Given this list of marker genes CASP8, UNC119 (unc-119 lipid binding chaperone), AP3B1, WDR1, CD28, RFXANK, ZAP70, TNFRSF1B, RFX5, CTPS1, RFXAP, WAS, CTLA4 (cytotoxic T-lymphocyte associated protein 4), MAGT1, IL2RA, IL2RB, PSMB10, DEF6, GATA2, CIITA, PGM3, RASGRP1, POMP, here is a description of the gene set: Human Gene Set: HP_ABNORMAL_CD4_CD8_RATIO Abnormal CD4:CD8 ratio studied in species Homo sapiens Any abnormality in the relative amount of CD4+ and CD8+ T lymphocytes.